Given this list of marker genes SMARCB1 (SWI/SNF related, matrix associated, actin dependent regulator of chromatin, subfamily b, member 1), KAT5, TRPV4, PYGL, SLC29A1, FBN1, FOXK1, IL6, NCOA5, APPL2, KLF15, GCGR, RAB11FIP2, ADRA2A, GCLM (NCBI Gene Id 2730), SLC2A4, CNR1, PAX2, CCDC186, FGFR4, C2CD2L, PPARG, PIK3CA, NPTX1, MPC2, SLC2A2 (NCBI Gene Id 6514), NR1H4, PAX6, IRS2, OBP2A, RBM4, TREM2, ADIPOR2, FOXA3 (forkhead box A3), PLSCR3, SRI, PDK4, G6PC1 (NCBI Gene Id 2538), CDK16, SERPINF1, RAF1, HNF1A, SIN3A, MIR320C2, GUCA2B, SLC16A1, SLC12A7, MTNR1B, TRPA1 (transient receptor potential cation channel subfamily A member 1), NKX6-1, DYNLL1, SESN2, CRY1, FOXO1, CMA1, UBTF, LEPR, MIR103A1, PDK2, SLC37A4, GPER1, SYBU, COL1A1, ADIPOR1, ALOX5, ZNF236, PPP1R3G, C1QTNF12, PDX1, MIR320A, FBN2, RBP4, INSR, AGER, VSNL1, ADIPOQ, MIR337, PDE8B, ADGRF5, SRF, OSBP, G6PC2, PTPN11, GCG, IGFBP5, PIH1D1, NCF1, PRKAA1, VGF, PTPRN, HK1 (NCBI Gene Id 59333), MBD5, IRS1, USF1, NGFR, KCNB1, HK2, RPH3AL, RAC1, FOXO3, MCU, FOXA1, SIRT6, MIR16-1, MIR320B2, STAT3, PTCH1, GHRHR, FUT1, DHPS, SMARCA4, MIR320D2, ADCY8, ERN1, PRKAA2, SESN3, PTPN2, HKDC1, PFKM, PPARD, CSRP3, ERO1B, RAB11FIP5, CYBA, WFS1, GCK, GPR68, PIK3R1, TUNAR, BAIAP3, STXBP3, PLA2G6, SLC12A6, SLC9B2, FFAR1 (free fatty acid receptor 1), SMAD3, PPP3CB, GPRC6A, INS, RACK1, EPHA5, FOXK2, ADISSP, HNF4A, AKT1, OXCT1, BAD, SELENOT, MLXIPL, ASPSCR1, TCF7L2, STXBP4, ZBTB20, SSTR5, RPTOR, ABCC8, UCP2 (uncoupling protein 2), ZBED6, TGFB1, PTPRJ, ICAM1, FOXA2, TENT4B, PRKACA, CSMD1, BGLAP, CLTRN, GPR27, PIM3, TRA2B, CRTC2, NADK, CYP7A1, HIF1A, PTPRN2, GATA4, RRAGA, PRKN, PCK2, SIRT1, PRCP, PHPT1, IGF1, TSC22D4, SGCB, ACSM2A, GCKR, MIR320B1, GPX1, OGT, MIR320C1, CMKLR2, XBP1, PPARGC1A, NR1D1, SUCNR1, PRKCE, TRPM4, OAS1, GPR21, IER3IP1, RAB11B, STK11, LIN28A, CRY2, RMI1, STX4 (NCBI Gene Id 6810), PCK1, ENY2, CARTPT, CDKN2A, ENDOG, ABCA12, GPLD1, POMC, GAS6, RFX6, LEP, USF2, OPRK1, LRP5, SLC30A8 (NCBI Gene Id 169026), CCN4 (cellular communication network factor 4), IGF1R, RPS6, CASR, SOX4, DUSP29, KLF7, BECN2, SIDT2, GCLC, BACE2, PIK3R2, GHRL, DBH, KCNK16, NOX4 (NADPH oxidase 4), CYP11B1, LRRC8A (NCBI Gene Id 56262), INPP5K, FABP5, NEUROD1 (neuronal differentiation 1), GJB6, CAV3, FFAR2, SLC39A14, BRSK2, MIR320D1, TRPM5, MIRLET7G, SMAD4, LRRC8D, NDUFAF2, FKBP1B, GPI, NUCKS1, BHLHA15, PARK7, CYB5R4, HK3, UNC13B, SLC8B1, EFNA5, FOSL2, FIS1, MIR146A, HECTD4, CFTR, ANO1, MIR15A, CEBPA, CRH, MIR33A, HLA-DRB1, MIR320E, JAGN1, ADCY5, MUSTN1, here is a description of the gene set: Human Gene Set: GOBP_CARBOHYDRATE_HOMEOSTASIS species: Homo sapiens A homeostatic process involved in the maintenance of an internal steady state of a carbohydrate within an organism or cell.